Given this list of marker genes CMTM5, LINC02895, PRKG2, RTP5, PID1, MYRF, DMRT2, UGT8, SCRG1, PMP2, SNORA74D, H1-9P (H1.9 linker histone, pseudogene), CYP2J2, COL20A1, MROH9, ASIC4, ASB5, NBEAP2 (neurobeachin pseudogene 2), KLRC3, TNR-IT1, PCDH20, KRT18P11, OLIG1, FMO3, B3GNT7, GDNF, KLRK1, PTCSC3, MIR4307HG, MAG, LINC02283, C10orf90, CLDN11, VSX1, LINC03048, GPR17, DCAF4L2, MIR219A2HG, NKX2-2-AS1, LINC01581, LINC02293, ART3, GDNF-AS1, KLRC4-KLRK1, MSC-AS1, HMGB1P29, ENSG00000259072, HR, HMX1, PCDH15, PPP2R2B-IT1, GDF6 (NCBI Gene Id 9571), VXN, CA10, TMPRSS9, RLBP1, ENSG00000236494, LINC00575, PLXNB3, SLC44A1, MKRN9P, LINC02277, BCAS1, RNU6-994P, ERBB3, TNR, AGMO, LGR5, LINC02294, ZNF365, NR0B1, CCDC26, RNU6-687P, ARHGEF3-AS1, LINC01254, LINC00924, PDGFRA, LINC01170, ASIC4-AS1, KLRC4, KLRK1-AS1, LINC01896, ROCR, SOX10, COL11A1, NOVA1-DT, ARC (NCBI Gene Id 53837), GALNT13-AS1, GALNT13, SLPI, PCDH11Y, ENSG00000234173, PLAAT1, CFHR5, GAL3ST1, KLRC2, CHAD, NPAS1 (neuronal PAS domain protein 1), MOG, DBX2, BMP8B, LHFPL3-AS1, NT5E, TMEM100, APOD, HAPLN1, LHFPL3, PRKCQ, OLIG2, KRT18P10, LINC01579, ENPP6, LINC01776 (long intergenic non-protein coding RNA 1776), EYA1, MYBL1, LINC00901, here is a description of the gene set: studied in species Homo sapiens Human Gene Set: DESCARTES_FETAL_CEREBELLUM_OLIGODENDROCYTES from publication Cao J, O'Day DR, Pliner HA, Kingsley PD, Deng M, Daza RM, Zager MA, Aldinger KA, Blecher-Gonen R, Zhang F, Spielmann M, Palis J, Doherty D, Steemers FJ, Glass IA, Trapnell C, Shendure J (PMID 33184181) Marker genes curated from the annotated cluster as represented in the Descartes Human Gene Expression During Development database. The gene expression program underlying the specification of human cell types is of fundamental interest. The study authors generated human cell atlases of gene expression and chromatin accessibility in fetal tissues. For gene expression, the study authors applied three-level combinatorial indexing to >110 samples representing 15 organs, ultimately profiling ~4 million single cells. The study authors leveraged the literature and other atlases to identify and annotate hundreds of cell types and subtypes, both within and across tissues. Our analyses focused on organ-specific specializations of broadly distributed cell types (such as blood, endothelial, and epithelial), sites of fetal erythropoiesis (which notably included the adrenal gland), and integration with mouse developmental atlases (such as conserved specification of blood cells). These data represent a rich resource for the exploration of in vivo human gene expression in diverse tissues and cell types.